The following is a description of a gene set: Human Gene Set: GOCC_LEWY_BODY Cytoplasmic, spherical inclusion commonly found in damaged neurons, and composed of abnormally phosphorylated, neurofilament proteins aggregated with ubiquitin and alpha-synuclein. species: Homo sapiens, and this is the list of marker genes: SQSTM1, GPX1, FBXO7, ARIH1, HERPUD1, PINK1, ATF4, PRKN, NUB1